Given this list of marker genes COL11A1, LMNA, HHAT, ZMPSTE24, PCNT, TBCE, here is a description of the gene set: Thin clavicles Abnormally reduced diameter (cross section) of the clavicles. Human Gene Set: HP_THIN_CLAVICLES studied in species Homo sapiens